The following is a description of a gene set: Neighborhood of CDKN1C Human Gene Set: GNF2_CDKN1C Neighborhood of CDKN1C cyclin-dependent kinase inhibitor 1C (p57, Kip2) in the GNF2 expression compendium species: Homo sapiens, and this is the list of marker genes: PSG3, PSG1, KISS1, MAFF, PSG7, GDF15, PSG9, CRH, GH2 (NCBI Gene Id 2689), HSD17B1, HSD3B1, PSG5, CAPN6, SEMA3B, ALPP, ADAM12, SVEP1, PAPPA2, EGFL6, LEP (NCBI Gene Id 3952), GCM1, CDKN1C, PSG2, TIMP2 (NCBI Gene Id 7077), PSG4, MAN1C1, CYP19A1